Given this list of marker genes FABP5, RXRA, FCN1, GLRA2, RBP7, UGT1A6, UBR2, GRIN1, GRHPR (glyoxylate and hydroxypyruvate reductase), NR2F2, NDUFAB1, GRM7, CYP2W1, GSTM2, SLC46A1, CYP26C1, ALB, GSTP1, SNCA, SIGLEC9, OXER1, FTCD, SLC38A9, PCK1, ACOX1, FOLR2, THNSL2, P4HA3, SIGLEC12, FOLR3, GRIN2D, GLRA1, PPIA, HIF1AN, ACOX3, EGLN3, UCP1, RTN4R, GFRA2, SHMT1, AKR1C4, DHFRP1 (NCBI Gene Id 643509), FABP7, UGT2B17, SRR, FURIN, TM4SF5, UROS, ACACB, SIGLEC8, SIGLEC11, UBR1, RBP5, EGLN2, YARS2, OGFOD3, AMBP, GCLC, PLA2G1B, PLOD2, DBH, FABP12, FABP3, S100A8, SESN1 (sestrin 1), ACOX2, ACOXL, RYR2, MCCC1, TNFRSF11B, ST8SIA2, CCDC144A, TMEM175, SLC1A3, FABP9, FABP4, ADH5, PRR7, FFAR4, FABP2, CYP26B1, GLUD1, GLUD2, PCCA, AKR1C3, AKR1C1, CRABP1, PHYH, PYGL, GLDC, CYP27C1, GLRA3, APOC1, UGT1A7, SELP, SIGLEC16, CAD, SIGLEC14, SH3GLB1, P3H3, CYP26A1, ALOX5AP, VDR, IGF2R, NRTN, SELL (selectin L), SERPINA5, FTCDNL1, ID3, CPS1, GOT1, FABP6, CYP4F11, PLOD1, IZUMO1R, FOLR1, CD22, OGFOD1, SLC19A1, EPDR1, SIGLEC7, MTHFS, AGRN, MAG, CD33, GNMT, PC, P4HTM, ST8SIA3, DHFR, P3H2, SIGLEC6, SLC7A6, PGD, NR1H4, GLRB, STX3, CRABP2, NOS1, UGT1A1, PTGDS, UGT2B15, RARA, S100A9 (NCBI Gene Id 6280), SCP2, LCN12, PAM, APP, SIGLEC5, FABP1, OGFOD2, UGT1A8, HNF4A, CASTOR2, P4HA2, RBP1, UGT2B4, PPARG, LRAT, GRIN2B, CASTOR1, MDK, P4HA1, GPR143, PSAP, NOS3, GSTA1, SESN3, NAPEPLD, PMP2, UGT1A10, SIGLEC10, DMBT1, NOS2, ADIPOQ, UGT2B7, DBT, EGLN1, TYMS, RARS1, ALKBH3, P3H1, PLOD3, SELE, RBP2, GRIN3A, GPR31, UGT1A3, FABP5P3, P2RX1, HLCS, ST8SIA4, GRIN3B, PPARD, SESN2, NOD2, UGT1A9, AKR1C2, UGT1A4, here is a description of the gene set: studied in species Homo sapiens Binding to an organic acid, any acidic compound containing carbon in covalent linkage. Human Gene Set: GOMF_ORGANIC_ACID_BINDING